Given this list of marker genes Gabra5, Slitrk4, Npy2r, Deaf1, Nr2e1, Grik2, Brinp1, Ext1 (NCBI Gene Id 14042), Taar4, Large1, Cck, Ephb2, Adra2a, Comt, Penk, Htr1a, Shank3, Spire1, Slc1a1, Drd1, Rps6kb1, Asic4, Vdac3, Dbh, Dbi, Atp1a2, Mecp2 (NCBI Gene Id 338503), Ankfn1, Gng7, Mdk, Mapk8ip2, Cckbr, Grin2b, Fbxl20, Mef2c, Bcl2, Htr2c, Crhr1, Eif4g1, Apoe, Pde8b, Neurod2, Morc1, Npas2, Dpp4, Eif4e, Kctd16 (NCBI Gene Id 77524), Prkar1b, Asic1, Grpr, Gja1, Vdac1, Drd4, Bdnf, Atp1a3 (ATPase, Na+/K+ transporting, alpha 3 polypeptide), Rag1, Adrb1, Als2, Usp46, Adcyap1, Grm7, Grp, Lypd1, Esr2, Ucn, Crh, Cacna1e, here is a description of the gene set: Mouse Gene Set: GOBP_FEAR_RESPONSE species: Mus musculus The response of an organism to a perceived external threat.